The following is a description of a gene set: Human Gene Set: GOBP_MODIFIED_AMINO_ACID_TRANSPORT species: Homo sapiens The directed movement of modified amino acids into, out of or within a cell, or between cells, by means of some agent such as a transporter or pore., and this is the list of marker genes: SLC6A13, LRP2, SLC7A11, ABCC5, SLC38A2, SLC6A14, SLC22A15, SLC22A4, ABCC4, SLC1A4, ABCC1, NHERF1, CTNS, SLC25A39, FOLR1, SLC7A6, FOLR3, SLC19A1, SLC22A16, SLC5A6, SLC16A12, SLC25A40, SLC6A20, SLC25A20, SLC7A13, GJA1 (gap junction protein alpha 1), PDPN, SLC16A9 (solute carrier family 16 member 9), PDZK1, SLC22A5, SLC25A32, SLC6A12, SLC13A3 (solute carrier family 13 member 3), SLC3A1, SLC46A1, SLC19A2, SLC22A1, SLC7A9, SLC6A8, FOLR2, SLC25A29, MGST1